The following is a description of a gene set: species: Homo sapiens Human Gene Set: GOBP_R_LOOP_PROCESSING A DNA metabolic process that results in the disassembly of R-loops. R-loops are three-stranded nucleic acid structures consisitng of an RNA:DNA heteroduplex and a looped-out non-template strand. Aberrant formation and persistence of R-loops block transcription elongation and cause DNA damage. Mechanisms that resolve R-loops are essential for genome stability., and this is the list of marker genes: MRE11, DDX23, SRPK2, DDX21, SIRT7, RAD50 (RAD50 double strand break repair protein), NBN, PRIMPOL, NFAT5